The following is a description of a gene set: Human Gene Set: NR5A1_TARGET_GENES Genes containing one or more binding sites for (NR5A1) in their promoter regions (TSS -1000,+100 bp) as identified by GTRD version 20.06 ChIP-seq harmonization. species: Homo sapiens from publication Yevshin I, Sharipov R, Kolmykov S, Kondrakhin Y, Kolpakov F (PMID 30445619), and this is the list of marker genes: TFRC, CHIT1, GFI1B, ZNF747 (zinc finger protein 747), GLRA1, MIR6881, HTR5A, WASH6P, CYB5R4, PKM, MIR548AW, SNAP25-AS1, SEMA7A, BARHL1, PALM, MIR7-3HG, LINC02684 (long intergenic non-protein coding RNA 2684), ZNF747-DT (NCBI Gene Id 107984875), TSC1